Given this list of marker genes Rab38, Cd63, Bloc1s5, Ankrd27, Bloc1s3, Rab32, Ap3d1, Ap1m1, Bloc1s6, Ap1g1, here is a description of the gene set: studied in species Mus musculus Steps required to form a membrane-bounded organelle into a pigment granule containing pigment. Maturation is a developmental process, independent of morphogenetic (shape) change, that is required for a cell or structure to attain its fully functional state. Mouse Gene Set: GOBP_PIGMENT_GRANULE_MATURATION